Given this list of marker genes CHMP4B, DNM1, SORT1, PARP2, GATAD1, ASXL1, TMOD2, RNF44, CTNNB1, LYPLA2, AP2A1, MYF5, KRCC1, PENK, ZNF518B (zinc finger protein 518B), B3GNT5, VAMP1, IGFBP4, CRTC2, PUF60, MANSC1, RBM17, TRAF3, VN1R5, GOLGA7 (NCBI Gene Id 51125), HPCAL1, PDE1B, MDFIC, ARF3, AMBRA1, HNRNPD, DNAH1, ARHGEF18, PSMG2, MPZ, SETD6, HLX, OAS3, TMEM63A, SERPINB6, TFAP2C, GOLGA2, PDK4, SLC15A5, COL4A6, OLIG2, TNFAIP2, BLTP3A, F11R, ITGB7, UBA7, KCNK13, FHL1, F5, PAX1, MAP1LC3A, SLC7A3, ABCD1, CCNK, OSGEP, HMX3, NCK2, RNF25, DHRS3, ARHGDIA, SNX3, ADD1, ANXA13 (NCBI Gene Id 312), DGKG, DNAJC14, FAM53C, BCL9, PDCD6, PTDSS1, BASP1, NEK9, INCENP, PELO, HOMER2, FCGR3A, PPP1R21, NFATC2IP, SF3B1, MCUB, RTN1, GYS1, HMGA1, PAQR7, MNAT1, UXS1, YWHAE, AGRN, EPN1, GGCX, MAP4K4, TMEM131, ABL1, MYL12B, TMCO6, ARHGAP35, TPCN2, GTF2H4, IKBKB, SPHK2, FRYL, EN2, ANKRD13C, TMEM184B, MKNK1, FBXW12, RPAP3, MOCOS, DENND5A, SLC37A4 (NCBI Gene Id 84965), C2CD2L, TMEFF2 (NCBI Gene Id 51753), COL3A1, PPP2R2A, TNIP1, MARK4, NFATC2, SLFN13, GPATCH4, BRAP, DNAJC30 (NCBI Gene Id 84277), OCSTAMP, KRTAP21-1, VPS9D1, PAPSS1, HEY1, MOB3B, ALDH1L1, TNPO2, NOTCH1, SYNRG, BACH1, SF1, PCDH20, TKT, ZNF281, USP26, MED15, KIAA0930, MARCHF5, ZNF598, RFXAP, SLC27A2, KTI12, BCKDHB, ARHGEF40, EPB41L1, RNF135, SLC25A51 (solute carrier family 25 member 51), DNMT1, FNTB, TAF13, NACC1, APP, NCOA5 (nuclear receptor coactivator 5), SHKBP1, TIMM9, MAGIX, GPANK1, GIT1, RGS14, RCOR3, FBXO28, SOX11 (NCBI Gene Id 6664), B3GAT3, CCL25, LRBA, SHOC2, LDLRAP1, COX8A, ARIH2, ARSG (arylsulfatase G), LPAR3, ADAM19, TGFB2, NT5M, PSD3, C6orf136, NCOR1 (nuclear receptor corepressor 1), MAP6, MGLL, IRAG1, TARBP2, EYA3, CDH2, GPR180, RETREG2, ANAPC7, TAP1, FBXW11, PPP2R5B, CUL2, FAM149B1, SNX12, ALG2, SELENBP1, here is a description of the gene set: from publication Amit I, Garber M, Chevrier N, Leite AP, Donner Y, Eisenhaure T, Guttman M, Grenier JK, Li W, Zuk O, Schubert LA, Birditt B, Shay T, Goren A, Zhang X, Smith Z, Deering R, McDonald RC, Cabili M, Bernstein BE, Rinn JL, Meissner A, Root DE, Hacohen N, Regev A (PMID 19729616) Genes down-regulated in comparison of dendritic cells (DC) stimulated with CpG DNA (TLR9 agonist) at 0.5 h versus DC cells stimulated with Gardiquimod (TLR7 agonist) at 0.5 h. Human Gene Set: GSE17721_CPG_VS_GARDIQUIMOD_0.5H_BMDC_DN species: Homo sapiens mouse primary BMDCs were stimulated with tlr ligands and gene expression changes were profiled on Affymetrix arrays